The following is a description of a gene set: We have compared histologic features and gene expression profiles of newly identified plasmacytomas from NFS.V(+) congenic mice with plasmacytomas of IL6 transgenic, Fasl mutant, and SJL-beta2M(-/-) mice. NFS.V(+) tumors comprised an overlapping morphologic spectrum of high-grade/anaplastic, intermediate-grade/plasmablastic, and low-grade/plasmacytic cases with similarities to subsets of human multiple myeloma and plasmacytoma. Microarray and immunohistochemical analyses of genes expressed by the most prevalent tumors, plasmablastic plasmacytomas, showed them to be most closely related to immunoblastic lymphomas, less so to plasmacytomas of Fasl mutant and SJL mice, and least to plasmacytic plasmacytomas of IL6 transgenic mice. Plasmablastic tumors seemed to develop in an inflammatory environment associated with gene signatures of T cells, natural killer cells, and macrophages not seen with plasmacytic plasmacytomas. Plasmablastic plasmacytomas from NFS.V(+) and SJL-beta2M(-/-) mice did not have structural alterations in Myc or T(12;15) translocations and did not express Myc at high levels, regular features of transgenic and pristane-induced plasmacytomas. These findings imply that, as for human multiple myeloma, Myc-independent routes of transformation contribute to the pathogenesis of these tumors. These findings suggest that plasma cell neoplasms of mice and humans exhibit similar degrees of complexity. Mouse plasmacytomas, previously considered to be homogeneous, may thus be as diverse as their human counterparts with respect to oncogenic mechanisms of plasma cell transformation. Selecting specific types of mouse plasmacytomas that relate most closely to subtypes of human multiple myeloma may provide new opportunities for preclinical testing of drugs for treatment of the human disease. species: Mus musculus Up-regulated genes that best disciminate plasmablastic plasmacytoma from plasmacytic plasmacytoma tumors. from publication Qi CF, Zhou JX, Lee CH, Naghashfar Z, Xiang S, Kovalchuk AL, Fredrickson TN, Hartley JW, Roopenian DC, Davidson WF, Janz S, Morse HC 3rd (PMID 17363561) Mouse Gene Set: QI_PLASMACYTOMA_UP, and this is the list of marker genes: Bag2, Tgfb1, Vav1, Hck, Rnase1, Fbxw8, Abi3, Rag1, Rgs16, Sox11, Irgm1, Blk, Gng11, Xcl1, Kit, Rassf2, Pdgfb, Cd53, Adcy7, Zyx, Batf, Mtpn, Tlr1, Btg1, Itgb2, Mfap1a, Il18bp, Ptpn6, Clu, Irf2, Ltb, Arf5 (NCBI Gene Id 11844), Irf1, Rras2, Stap1, Zap70, Zfp36l1, Traf1, Relb, Nr1h3, Rgl1, Clec4e, Casp4, Lgals9 (lectin, galactose binding, soluble 9), Mkrn1, Itgb7, Tln1, Dntt, Dpp4, Bcl2, Bhlhe40, Ccr5, Apaf1, Cd37, Pdlim7, Anxa11, Cd3g, Fscn1, Ppbp, Stk10, Ccr1, Wdr1, Epor, Sh3bp1, Gna15, Lrrfip1, Tgtp1, Snx2, Cd244a, Ptges, Nfkbie, Cd22, Phlda2, Rb1, Cst7, Hcls1, Ddt, Stk39, Rsad2, Casp6, Cdc42ep3, Ccl4 (NCBI Gene Id 20303), Plcl2, Tjp3, Il27ra, Cd40, Rbp4, Gnb4, Sh3bp2, Tlr9, Lsp1, Tubb3, Tnf, Iigp1, Tnfaip2, Tmod3, Itga6, Ptgs1, Gata1, Ccl19, Tmsb10, Klrd1, Lcp1, Ubash3b, Cdc42se1, Capg, Cd3d, Irf8, Sla, Pfn1, Cd82, Card11, Mob1a, Socs1, Plac8, Ccr2 (C-C motif chemokine receptor 2), Tnfsf13b, Arhgdib, Fgl2, Il21r, Vasp, Cish, Plscr1, Cib1, Plek, Plxnc1 (plexin C1), Ptpn1, Scin, Il20, Dapp1, Lck, Capn1 (calpain 1), Cd47, Prtn3, Hps3, Cap1, Myo10, Snx10, Myb, Lst1, Nfam1, Id2, Gng10, Il17rb, Pak1ip1, Pcsk6, Dnase1l2, Psmb9, Cnr2, Fgr, Stk17b, Cd3e, Ptpn18, Ankrd1, Gpsm3, Rgs1, Plekho1, Cd5l, Rp2, Tmbim6, Marco, Pstpip1, Cd19, Avil, Grb2, Sema4a, Il18, Nfkbia, Ptpn13, Cnp, Srf, Tmsb4x, Ccl3, Arap1, Tnfaip3, Csf1r, Psmb8, Ube2d1, Trim30a, Mta3, Frmd4b (NCBI Gene Id 97338), Cd7, Casp7, Spib (NCBI Gene Id 272382), Rassf4, Gbp2b, Axl, Ifngr1, Lasp1, Itgb1, Ciita, Trim21, Dok1, Marcks, Cnn2, Arrb1, Il18rap, Lag3, Arap2, Ifi35, Rabep2, Limk1, Flt3, Ehd1, Hrk, Il4ra (NCBI Gene Id 16190), Cd4, Il12a, Actg2, Pf4, Rrad, Mycn, Slc11a2, Sh2d1a, Arpc4, Pcsk1n, Igf1, Wtap, Slc43a3 (solute carrier family 43, member 3), Slamf1, S100a13, Zfpm1, Il1r2, Bdkrb2, Aoc1, Il2rg, Dnase1l3, Alox5ap, Tgm2 (transglutaminase 2, C polypeptide), Rps6ka1, Fas, Dek, Cd79a (NCBI Gene Id 12518), Trat1, Itgb3, Mmp10, Casp3, Swap70, Ly86, Plec, Tnfsf11, Lat, Sp100, Rac2 (NCBI Gene Id 19354), Dusp2, Actr2, Tnfrsf14, Dnajb1, Ccl5, Il2rb, Casp1, Tfeb, Ntn1, Il5ra, Tuba8, Gbp2, Arl6ip5